The following is a description of a gene set: species: Mus musculus Mouse Gene Set: REACTOME_ASSEMBLY_AND_CELL_SURFACE_PRESENTATION_OF_NMDA_RECEPTORS Assembly and cell surface presentation of NMDA receptors, and this is the list of marker genes: Grin3a, Grin1, Grin2c (glutamate receptor, ionotropic, NMDA2C (epsilon 3)), Grin2a, Grin2d